Given this list of marker genes Eif4a3l2, Srp9, Cpeb2, Cpeb3, Eif4a3l1, Shfl, Rack1, Eif4a3, here is a description of the gene set: Any process that stops, prevents, or reduces the frequency, rate or extent of translational elongation. Mouse Gene Set: GOBP_NEGATIVE_REGULATION_OF_TRANSLATIONAL_ELONGATION species: Mus musculus